Given this list of marker genes Psmc3, Psmb9, Psma2, Rpn2, Psmc5, Psmb4, Psmb10 (NCBI Gene Id 19171), Uchl1, Psmd5, Psma4, Psmd7, Psme2, Psmb2, H2-Q10, H2ax, Psmd12, Psmd9, Uba1, Psma3, Psmb5, Psma5, Psmd11, Psmc2, Psmd6, Ube2d1, Psmc4, Ubb, H2az1, Psmb7, Ube2b, Psmb1, Psme3, Ube2d3, Psmc6, Ifng, Rpn1, Psmd3, Uba7 (ubiquitin-like modifier activating enzyme 7), Psmd2, Psmc1, Psma7, Psmd13, Psma6, Uchl4, Psme1, Psmd8 (proteasome (prosome, macropain) 26S subunit, non-ATPase, 8), Psmb6, Psmd4, H2ac22, Nedd4, Ube2d2a, here is a description of the gene set: Proteasome degradation species: Mus musculus Mouse Gene Set: WP_PROTEASOME_DEGRADATION